Given this list of marker genes CTCF, MPHOSPH8, MYC, ZNF445, USP7, BRCA1, EHMT2, DNMT1 (NCBI Gene Id 1786), UHRF2 (NCBI Gene Id 49857), MECP2, DNMT3L (NCBI Gene Id 29947), UHRF1, HELLS, WT1, PRMT5, DNMT3A, here is a description of the gene set: An epigenetic gene regulation mechanism that negatively regulates gene expression by methylation of cytosine residues in chromosomal CpG islands. CpG islands are genomic regions that contain a high frequency of the CG dinucleotide associated with the transcription start site of genes. Human Gene Set: GOBP_NEGATIVE_REGULATION_OF_GENE_EXPRESSION_VIA_CHROMOSOMAL_CPG_ISLAND_METHYLATION species: Homo sapiens